Given this list of marker genes TENM4, ITGA6, SRPX, PDE2A, CBLN1, SLC22A18AS, CA12, NAB2, RYR3, SMARCD3, ALDH7A1, PTPRN, SLC2A3, HRAS, SV2B, SOX4, OLFM1, NUPR1, HBB, EFNA2, C3, RAC3, TFAP2B, VCAN, TYRO3, GNG4, FEZ1, CALB1, PLAAT3, MAP7, KCNJ4 (NCBI Gene Id 3761), SLC17A7, ALDH1A3, TUSC3 (NCBI Gene Id 7991), GJA1, SCN2B, CHST15, FEV, RUNDC3A, THBS2, SULT4A1, APBB1, BCAS1, NCAN, RND1, PLEKHB1, PLCB2, AMPH, GABBR1, WIF1, NPTX1, CLDN5, PSG7, PHYHIP, ANOS1, RELN, EPHA4, SNPH, ARNT2, THRA, NRXN1, BCL9, PSPHP1, DPYSL3, PRSS2, BMERB1, APBA2, TAGLN3, VSNL1, SLC39A6, SCG2, TCEAL4 (NCBI Gene Id 79921), GFAP, PENK, CBX6, RAB31, CHRNB1, GPX3, PKD1, PRPF19, STMN2, ASIC1, LZTS3, INSIG1, NR1D1, DDX3Y, DIRAS3, NEFM, DNAJB2, CX3CR1, MPP3 (MAGUK p55 scaffold protein 3), SNRK, GRIK5 (NCBI Gene Id 2901), HTR4, ST3GAL5, PITPNB, CLDN10, ABCA3, ZIC1, ATP6V1G2, TLE1, PDE4B, MEF2C, SCHIP1, PTPRO, TRPC4AP, SNCB, RHOB, ATP6V1D, ELF3, CDH11, SST, SYNE1, ARC, SV2A, RUNX1T1, ZIC2, DCLK1, CDK18, PDGFRA, RGS4, UBXN1, TSPAN8, KCNK1, PDE8B, HTRA1, GRIN1, PCK1, GBF1 (golgi brefeldin A resistant guanine nucleotide exchange factor 1), KIF5C, DDX17, LARGE1, FOLR2, ALDH4A1, CYB5R1, MAOB, FGB, KMT2A, CHN2, CTSF, DBP, DBN1, ITM2A, ABCC5, GSTA4, SOD3, FADS2, CSPG5, SPP1, SORBS2, GUCY1B1, INPP1, AQP4, LY6H, STMN1, RNF144A, RHBDL1, GNG7, EFS, TBR1, CACNB3, DYNC1I1, ACD, SIX6, CHST1, MAT1A, EEF1A2, SYT1, KRT4, SPARCL1, NRGN, MYO10, CRYAB, TNF, FRZB, RIMS2, GET1, BCL11A, MBP, GAP43, AHDC1, MT1G, DPP6, SCN1B, CRYM, EDNRB, LIPA, MEIS2, KAT6B, STOML1, NID2, APOC4, COL6A2, POLR2J (NCBI Gene Id 5439), APOC1, NEO1, ITGA7, IFIT1, PKIA, MAOA, PRKCB, SELENOP, DUSP8, QDPR, UCHL1, SNCG, ALDH1A1, GPM6A, CLEC3B, RIMS3, PLXNA2, FABP7, DLG4, ANK3, GPRASP1, GABRB3, RND3, IFI27, RALGPS1, ATOSB, FAM107A, CHGB, APLP1, ADIRF, SPOCK2, CSRP2, THBS4 (NCBI Gene Id 7060), ALCAM, ITPKA, COL9A3, CRABP1, CITED1, CGA, POMZP3, AMT, ATP9A, NRG2, PCP4, NNAT, CA2, TACC2, WFDC2, RASL10A, MTHFR (NCBI Gene Id 4524), MAPRE2, ARHGEF4, TRIM23, GALR3, FOS, MLC1, BICD1, MYH11, PTGDS, ZBTB16, CRMP1, TMX4, FGFR2, CCND2, NFYC, TRIM9, TUBGCP4, FBXL7, L1CAM, LGR5, MLLT11, MAPT, KIF21B, LMO2, ACSL6, MTUS1, CEL, IGFBP3, KCTD17, RTN1, PRB4 (NCBI Gene Id 5545), ATP2B1, PLCH2, NECAB3, CADM1, ACSL1, CNTNAP2, GLRB, SLC23A2 (NCBI Gene Id 9962), PCDH9, MAGI2, TSPYL4, WDR7, VGF, TIMP3, TSPAN7, IQSEC1, PTK2B, SYT5, KYAT1, ABAT, CBR1, ATP6V0A1, PTP4A3, MYRF, CELF2, HAGH, NOVA2, GRIK1, GABRG2, MAPK10, SERPINI1, NTRK2, ANGPT1, ABLIM1, SOX10, S100B, EXD2, PCSK1, SCAMP5, CABP1, PSD, TIMM17B, UBL3 (NCBI Gene Id 5412), C1QB, TMSB15A, SH3BGR, ATP1B2, GJB1, SPOCK1, RBP1, SH3GL3, F3, AAK1, ABLIM3, CLIP3, RGS7, ALB, CACNG3, ADH1A, OMG, PARD6A, FAT1, EPHX1, TRO, PRPF6, NPY, CDKN1A, DUSP5, PRKCZ, NAP1L3, MAL, CSH2, CDH18, KRT86, RSBN1, RGS1, APOE, ENPP2 (ectonucleotide pyrophosphatase/phosphodiesterase 2), KIF3A, MDK, DVL1, PLCB1, EPN2, ORM2, SETBP1, PTN, GATM, FKBP1B, PPL, STK39, SGCE, CCK, CARTPT, GFPT2, PALM, KLK6, EFNB3 (NCBI Gene Id 1949), KCNA5, PARM1, CDH2, FZR1, TMCC2, ST6GALNAC4, GAGE12F, GNG12, TF, FGFR1, PRAME, CUL9, FAM131A, CALB2, MAP2, SLC1A3, ELAVL2, DCX, CORT, COX7A1, SPTBN2, MYLK, AANAT, KHDRBS3, ZBTB20, FOXG1, CKMT1B, TBC1D9, PHLDA1, GRIA2, CACNA2D2, NEBL, SCRN1, HMOX1, RGS5, HPR, DLK1, BTBD3, GABBR2, GADD45G, H2BC21, CDH22, SNAP25, FGF9, CEP135, INSM1 (INSM transcriptional repressor 1), TLE2, ATP1B1, BRD4, SCO2, TRIM2, ITPR1, MTMR9, PTPRZ1, DPYSL4, CA11 (NCBI Gene Id 770), SSTR2, EVI2A, FZD7, IGFBP2, RAB11B, PAX6, CDH4, GNAO1, EPAS1, B4GAT1, ABCC8, PER1, ELMO1, DNM1, NCALD, GPRC5B, ACTL6B, STAT2, PPP4R2, EPB41L3, STX1A, SLC1A6, FAT2 (FAT atypical cadherin 2), LDB2, TNC, APC2, MTSS1, DTNB, PCBP4, CKB, LHX2, CORO1A, AGT, CHGA, ST18, LMO4, PLXNB1, NEURL1, ARMCX2, PTPRD, COL9A2, FOXO4, RPH3A, WASF3, GAD1, NCAM1, GAL, SPHK2, MAPK8IP3, INHBB, QPCT, BAIAP3, PRKACB (NCBI Gene Id 5567), LAMA2, LDOC1, RASSF2, TSPYL2, NHERF1, TRPM2, PTPRN2, EDA, ELAC2, APOD, SERPINA1, NR4A1, SNAP91, PEG10, SCG5, ZBTB18, RPS4Y1 (ribosomal protein S4 Y-linked 1), PAX4, SEPTIN5, BIN1, SLC6A3, RNASE1, RBMS3, AQP1, CPE, DGCR2, PFKFB4, LPL, UBE2D1, CACNA1A, PPP3CA, FGFR3, NECAP1, PLP1 (NCBI Gene Id 5354), CFAP410, NOVA1, STXBP1, FXYD1, CELSR3, TM7SF2, DKK4, ENO2, SYNGR1, HSPA13, KLHDC3, CHL1, SOX9, CNP, ROR1, DMBT1, SERPINA3, ELAVL4, TMEM47, MXD4, LHB, MEGF9, RCAN2, MACIR, GSTM1, HSPA2, ATP2B2, AKR1C1, CD24, GPC3, SFRP1, CAPN3, IGFBP6, MAPK8IP2, SLIT1, NEFL, ARHGDIG, here is a description of the gene set: Human Gene Set: MODULE_66 species: Homo sapiens Genes in the cancer module 66.